Given this list of marker genes Psmb4, Ube2d1, Psmd7, Psma6, Psmd13, Anapc15, Anapc7, Anapc10, Psmc3, Psmc6, Psma5, Cdc26, Psmc4, Psmd6, Anapc2, Ube2c, Psmb5, Cdc23, Psmc1, Ubb, Psma1, Rps27a, Psmc2, Psma2, Psma3, Psmd1, Ube2e1, Psmc5, Psma7, Psma4, Psmb7 (NCBI Gene Id 19177), Psmd12, Psmb6, Ube2s, here is a description of the gene set: Reactome Pathway: APC/C:Cdc20 mediated degradation of Securin This event has been computationally inferred from an event that has been demonstrated in another species.<p>The inference is based on the homology mapping from PANTHER. Briefly, reactions for which all involved PhysicalEntities (in input, output and catalyst) have a mapped orthologue/paralogue (for complexes at least 75% of components must have a mapping) are inferred to the other species. part of: APC/C:Cdc20 mediated degradation of mitotic proteins species: Mus musculus electronically inferred by orthology from the curated human pathway